Given this list of marker genes EMC9, CERK, ENTPD4, DLG1, PEX2, MITF, STARD7, FAM114A1, IFT56, TCTN3, POLR1D, GTF2H5, USP34, GDE1, SPINT2 (serine peptidase inhibitor, Kunitz type 2), LASP1, AKT3, DBI, PIMREG, MMP24, CTNNAL1, P4HA2, PLPP2, SLC25A11, PRORP, AHNAK2 (NCBI Gene Id 730269), GYG2, PLAC8 (NCBI Gene Id 95621), NACC2, MTMR1, COMMD3, PLXNB1, MAN1A2, JUP, KDELR3, PRMT8, NKTR, UCP2, HMGB2, ABLIM1, GREM1, MED20, POU4F1, EIF4B, LRRC19, EML1, MAP3K9, ZNF706, MAEA, CRELD1, HMCES, ROR1 (receptor tyrosine kinase like orphan receptor 1), GPRC5B, ZNF185, GALNT10, RCN2, ADD2, ANTKMT, SLC33A1, NME7, ASF1B, FBXO9, PRSS23, SERPINE2, CNTN1, AP1S2, DNAJB9, CD2, CA12, ITGB5, MPC2, CNR2, GM2A, FIS1, HNRNPA0, CDK19, FSCN2, HTRA1, AQP3, APEX2, RAB4A, MYO5C, IDI1, PYGB, WSB2 (NCBI Gene Id 55884), ABCD3, PTPN6, ODC1, USP22, SMAGP, TBC1D2B, EPB41L1, DLEU1, CAP2, AHNAK, MARCKS, ADI1, PAGR1, UNKL, KLC1, TBL1X, FAM171A1, RABAC1, ARB2A, PCDHA3, PXDN, AP1M2, TMF1, MTMR2, PDXDC1, NIPSNAP1, ENO2, VLDLR, IGSF3, AMZ2, FBN2, STYXL1, SCARA3, MYH10, AOX1, JAG2, APMAP, TYRO3, PALLD, TTC3, TRIO, CD99, UNC119B, MGAT4B, EPB41L4B, SLC7A11, OLFML2A, ANKRD28, IPO9, IL17RB, PPP1R3C, HSPB8 (NCBI Gene Id 8097), NDRG1, ENTPD6, TMCO3, DHCR7, AHCYL1, LBR, HEBP2, HPCAL1, HSPA12A, TUBA1A, ZNF395, JAK1, NRCAM, PRC1, TRIM37 (NCBI Gene Id 4591), TMOD2, AGAP1, RAP1GAP, SLC3A1, GNG12, SNF8, RNF14, IKBKE, DIDO1, KANK2, GMFB, TRAK2, ARL3, MOCS2, CHST15, DLGAP5, NUAK1, PLCE1, NAT1, RAB40B, HAGH, CEP83, ACTR1B, CTDSPL, CREB3L2, MTCH1, ATP13A2, NPIPA1, DEPTOR, MALL, PTS, KRT19, PDLIM2, NOTCH2NLA, HBQ1, PERP, GALNT11, KIAA0232, NDE1 (NCBI Gene Id 95348), LRRC37A2, ABHD10, ASCC1, ADCK2, ADAM11, ZNF331, PRKAR2A, ILVBL, here is a description of the gene set: species: Homo sapiens Genes down-regulated in cells from peripheral lymph nodes: T reg versus T conv. We investigated at which stage of maturation commitment to a stable Foxp3-expressing phenotype takes place. We assessed stability of Foxp3 expression in thymic Foxp3+ Treg subsets of different maturity, defined by CD24 expression. Next we compared gene expression profiles of Foxp3+ Treg subsets (+) of different maturity (24lo, 24int, 24hi) and could identify a set of genes that were specifically up or downregulated in Foxp3+ Tregs, but not in Foxp3- conventional T cells, in a maturation-dependent manner. Human Gene Set: GSE42021_TREG_VS_TCONV_PLN_DN from publication Toker A, Engelbert D, Garg G, Polansky JK, Floess S, Miyao T, Baron U, Düber S, Geffers R, Giehr P, Schallenberg S, Kretschmer K, Olek S, Walter J, Weiss S, Hori S, Hamann A, Huehn J (PMID 23420886)